The following is a description of a gene set: studied in species Mus musculus Mouse Gene Set: GOBP_POSITIVE_REGULATION_OF_CELL_CYCLE_G1_S_PHASE_TRANSITION Any signaling pathway that activates or increases the activity of a cell cycle cyclin-dependent protein kinase to modulate the switch from G1 phase to S phase of the cell cycle., and this is the list of marker genes: Tbx1, Adam17, Ezh2, Rgcc, Cul4b, Apex1, Lsm10, Mepce, Gli1, Dbf4, Egfr, Ube2e2 (NCBI Gene Id 218793), Larp7, Rrm1, Stox1, Anp32b, Crebbp, Ccnd2, Ccnd1, Ccnd3, Rptor, Rrm2, Paf1, Cenpj, Plrg1, Csf1r, Cul4a, Tbx2, Ankrd17, Mblac1, Rdx, Ccne2, Plcb1, Akt1, D1Pas1, Rpl17, Cdc73, Hyal1 (NCBI Gene Id 15586), Fam83d, Sass6, Stxbp4 (NCBI Gene Id 320264), Tfdp1, Cyp1a1, Pagr1a, Aif1, Kmt2e, Crnn, Mdm2, Mtbp, Cpsf3, Tert, Ddr2, Eif4g1, Phb2, Anxa1, Ccne1 (cyclin E1), Plcg2, Adamts1, Pkp3, Ddx3x, Lsm11, Stil, Trp63, Kcna5, Fgf10